The following is a description of a gene set: studied in species Mus musculus Mouse Gene Set: GOBP_MEMBRANE_RAFT_LOCALIZATION Any process in which membrane rafts are transported to, or maintained in, a specific location. Membrane rafts are small (10-200 nm), heterogeneous, highly dynamic, sterol- and sphingolipid-enriched membrane domains that compartmentalize cellular processes., and this is the list of marker genes: Naxe, Yjefn3, Gsn, Ptprc, Dock2, Lat, Rala